Given this list of marker genes LIPT2, CCDC115, MAP3K12, TNRC18, CLUAP1, ZNF148, PLEKHM1, NHLRC3, FOXO1, ABL1 (NCBI Gene Id 25), EIF4ENIF1, MIR15A, UCK1 (NCBI Gene Id 83549), NANP, PIDD1, ACOX3, PLA2G15, ERCC5, USP37, UFSP1, PLK3, RHOBTB1, MLYCD, NGRN (NCBI Gene Id 51335), LYSMD1, ARRDC3, TSC22D4, ARRDC2, TSEN2, SLC26A11, SIRT4, F8A1, MAP3K1 (mitogen-activated protein kinase kinase kinase 1), RFXAP, C16orf54, TMEM86A, HEXIM2, GTF2IRD2, MFAP3, ZBTB45, SIRT7, CD68, STARD9, CPEB2, SLF2, TSSC4, DCAF5, SNX8, LPAR5, VHL, TBC1D14, RGS2 (NCBI Gene Id 5997), CEP250, CAMSAP2, OPLAH, MAGEF1, H2BC21, KIFC3, TAF3, ARF4, MRPL49, B3GNT8, IRF2BP2, PLD4, IGFLR1, KLHL42, VAMP1, TBL2, KCTD7 (potassium channel tetramerization domain containing 7), ZBTB38, TEF, S1PR1, TMEM186, ITPRIPL1, SEC22C, ZSCAN2, FOXO3, OTULINL, LRIG3, ARL11, LPAR6, RAB31, SASH3, POLG2, GIT1, MIR421, THAP11, MEF2A, CD300LB, MARVELD1, FAM120B, ARL4C, FAN1, SFMBT1, BTBD6, TRIM8, SPEG, RAB3A, B3GALT4, POLI, LSM14B, TBXAS1, PATZ1, PDIK1L, POLR1G, CCDC127 (coiled-coil domain containing 127), ASXL2, PVT1, LDLRAP1, KATNAL1, LMO2, ARID3B, PER1, AASDH, DNMBP, MNT, ELF2, LHFPL2, UQCC3, TRAPPC14, SLC25A42, PPP1R13B, BHLHE41, RUNDC1, TIGD2, DUSP7, FAHD1, PAOX, CDT1, TMCC2, SH2B3, RNF169, MED17, FLCN, FAM76B, TLK1, NPRL3, FHIP2B (NCBI Gene Id 64760), BBS1, TBC1D2, NCOA3, DEAF1, THUMPD2, FAM78A, ADAMTS10, ZBTB2, FOS (Fos proto-oncogene, AP-1 transcription factor subunit), LYL1, AKAP10, CASP9, IFFO1, KCTD2 (NCBI Gene Id 23510), HDAC5, GIT2, MIR19A, here is a description of the gene set: Genes up-regulated in macrophages: untreated versus LPS. Human Gene Set: GSE7348_UNSTIM_VS_LPS_STIM_MACROPHAGE_UP from publication Foster SL, Hargreaves DC, Medzhitov R (PMID 17538624) The inflammatory response initiated by microbial products signaling through Toll-like receptors (TLRs) of the innate immune system is essential for host defense against infection. Because inflammation can be harmful to host tissues, the innate response is highly regulated. Negative regulation of TLR4, the receptor for bacterial lipopolysaccharide (LPS), results in LPS tolerance, defined as hyporesponsiveness to repeated stimulation with LPS. LPS tolerance is thought to protect the host from excessive inflammation by turning off TLR4 signal, which then shuts down TLR-induced genes. However, TLR signaling induces hundreds of genes with very different functions. We reasoned that genes with different functions should have different requirements for regulation. Specifically, genes encoding proinflammatory mediators should be transiently inactivated to limit tissue damage, while genes encoding antimicrobial effectors, which directly target pathogens, should remain inducible in tolerant cells to protect the host from infection. Using an in vitro system of LPS tolerance in macrophages, here we show that TLR-induced genes may indeed be divided into two distinct categories based on their functions and regulatory requirements. Further, we show these distinct groups are regulated by gene-specific, and not signal-specific mechanisms. studied in species Homo sapiens